Given this list of marker genes ST3GAL3, ST3GAL5, ST8SIA3, LARGE1, B3GALNT1, FUT6, B3GNT5, A3GALT2, ST3GAL1, B4GALNT1, B4GALT6, ST6GALNAC4, ST6GALNAC3, B4GALT5, FUT9, TM9SF2, FUT2, FUT1, B3GALT1, B4GALT4, ST6GALNAC6, FUT4, ST8SIA2, A4GALT, ST6GALNAC5, FA2H, CERK, ST8SIA6, ST3GAL2, UGT8, PRKAA1, ST8SIA5, ST8SIA4, GAL3ST1, B3GALT2, UGCG, C20orf173 (NCBI Gene Id 730687), B4GALT3, ST8SIA1, B3GALT4, here is a description of the gene set: species: Homo sapiens The chemical reactions and pathways resulting in the formation of glycosphingolipid, a compound with residues of sphingoid and at least one monosaccharide. Human Gene Set: GOBP_GLYCOSPHINGOLIPID_BIOSYNTHETIC_PROCESS